The following is a description of a gene set: Human Gene Set: REACTOME_TRAF6_MEDIATED_INDUCTION_OF_TAK1_COMPLEX_WITHIN_TLR4_COMPLEX species: Homo sapiens TRAF6-mediated induction of TAK1 complex within TLR4 complex, and this is the list of marker genes: TAB3, UBC, TAB2, SARM1, TAB1, LY96, CD14, TICAM2, TICAM1, IRAK2, TLR4, UBB, TRAF6, RPS27A, UBA52, MAP3K7